The following is a description of a gene set: studied in species Homo sapiens A type of ventricular tachycardia that is characterized by variable QRS complexes within each lead (i.e., QRS complexes may be different from beat to beat). Human Gene Set: HP_POLYMORPHIC_VENTRICULAR_TACHYCARDIA Polymorphic ventricular tachycardia, and this is the list of marker genes: CASQ2, TRDN, KCNJ2, HCN4, RYR2, CALM2, CALM3, TECRL, CALM1, KCNJ5